The following is a description of a gene set: Any process that results in a change in state or activity of a multicellular organism (in terms of movement, secretion, enzyme production, gene expression, etc.) as a result of a stimulus indicating the organism is under stress. The stress is usually, but not necessarily, exogenous (e.g. temperature, humidity, ionizing radiation). Human Gene Set: GOBP_MULTICELLULAR_ORGANISMAL_RESPONSE_TO_STRESS species: Homo sapiens, and this is the list of marker genes: LPAR5, GRP, HTR1A, SLC1A1 (NCBI Gene Id 6505), BRINP1, MAPK8IP2, PPP3CA, P2RX3, HMGCS2, TAC1, LYPD1, ANKFN1, HCN1, NPAS2, COL6A1, SCN9A, MTOR, RELN, ZNF212, EPHB2, USP46, P2RX4, GRIK2, GRPR, CRHR1, PDE8B, SCN3A, HTR2C, ASIC1, TMEM74, EIF4E (NCBI Gene Id 1977), GABRA5, SLITRK4, UCN, NMUR2, VWA1, NOS1, TACR1, RPS6KB1, APOE, DEAF1, MEF2C, SCN11A, THBS1, UMOD, DRD4, IDO1, EXT1, CAPN2, TRPA1, MECP2, PTEN, ADRA2A, TRPV1, SELENON, NTRK1 (NCBI Gene Id 7825), LRP11, PENK, FBXL20, ATP1A2, NEUROD2 (NCBI Gene Id 4761), PIRT, TSPO, DRD1, LARGE1, MORC1, MDK, BCL2, ATAT1, GRM7, VDAC3, ASIC4, ADRB1, NR2E1, EIF4G1, PRKCG, EDNRB, NPY2R, SLC6A2, P2RX2, GCH1, NR4A2, GRIA1, ADCYAP1R1, ALS2, GNG7, PRKAR1B (NCBI Gene Id 645590), KIAA0319, DBH, COMT, AKT1, DPP4, RAG1, KCTD16, RET, CRH, ADAM11, THBS4, VDAC1